Given this list of marker genes RIPK4 (NCBI Gene Id 54101), CHRNG, IRF6, GPC6, CHUK, PITX1 (NCBI Gene Id 5307), BHLHA9, MYH3, here is a description of the gene set: Popliteal pterygium Human Gene Set: HP_POPLITEAL_PTERYGIUM A pterygium (or pterygia) occurring in the popliteal region (the back of the knee). species: Homo sapiens